Given this list of marker genes H4c17, Smarca5, Babam1, H2bc9, H2bc7, H2bc8, Mdc1, Eya3, Trp53, H2bc27, H2ax, H4c8, Nbn, H4c18, H2bc12, H4c9, Rps27a, H4c4, H4c6 (NCBI Gene Id 319157), H4c14, H2bc11, Apbb1, H4c3, Pias4, H2bc15, Mapk8 (NCBI Gene Id 26419), H2bc1, H4c1, H4c11, Trp53bp1 (transformation related protein 53 binding protein 1), Brca1, Mre11a, H4c2, H4c12, H2bc13, H2bc22, Ube2n, Kat5, Bard1, Sumo1, Chek2, Eya1, Brcc3, Rnf168, Ubb, H2bc3 (NCBI Gene Id 319178), Ppp5c, here is a description of the gene set: Reactome Pathway: DNA Double Strand Break Response studied in species Mus musculus part of: DNA Double-Strand Break Repair This event has been computationally inferred from an event that has been demonstrated in another species.<p>The inference is based on the homology mapping from PANTHER. Briefly, reactions for which all involved PhysicalEntities (in input, output and catalyst) have a mapped orthologue/paralogue (for complexes at least 75% of components must have a mapping) are inferred to the other species. electronically inferred by orthology from the curated human pathway